Given this list of marker genes IFITM1, CCL18, DCTN3, GNLY, C3AR1, IL32, CXCR6, S100A4, TNFSF13, FAP, CXCL12, FADS1, VCAM1, CSF1R, CCR5, CD151, SPARC, CCN1, IFITM3 (interferon induced transmembrane protein 3), TNFAIP6, TIMP1, AIF1, GAS6, CD14, TIMP3, FTL, TBC1D8B, ITGB2, SRRM2, A2M, CD63, THBS1, GZMK, APOL3, LAG3, VMP1, CPM, IL3RA, DES, BBS2, FCGR1A, IER3, CTSL, FCGR2A, GBP1, CEBPD, NXPH3, LPAR6, PDGFRB, DLC1, VWF, IL1R1, IFI30, GPX1, CCR1, CYP1B1, HLA-DOA, CCL21, ZNF347, MYLK, EARS2, CCL5, TYROBP, CTSB, LYZ, CCL14, MGLL, PDGFRA, MMP1, CCND2, PCDH9, MMP9, VIM, IFITM2, CXCL9, CYP27A1, LMO2, DAB2, TIMP2, HBA2, FN1, MAPK12, FCER1G, MMP2, KCTD12, CCR2, LGMN, ITGB5, CDH13, CCL11, FTH1, TNFSF10, FPR1, PLPP3, CYBB, IL2RB, GJB1, DAPK1, CCL2, GBP2, here is a description of the gene set: Human Gene Set: MODULE_170 Immune response. species: Homo sapiens